The following is a description of a gene set: Human Gene Set: MIR1266_3P from publication Chen Y, Wang X (PMID 31504780) Genes predicted to be targets of miRBase v22 microRNA hsa-miR-1266-3p in miRDB v6.0 with MirTarget v4 prediction scores > 80 (high confidence targets). studied in species Homo sapiens, and this is the list of marker genes: DDX3X, RAP2A, TANGO6, ATP6V1A, BHMT2, FZD2, ZPR1, FLG2, TRAM1, SNRNP27, UQCR11, AMOTL1, PPP4R2, POGLUT3, SIX4, CDH13, FAM118A, CCT5, AOPEP, ABCB10, SENP6, GTF2H5, MYO1B, ZNF227, USP8, TAF5, CXCL2, RAB23, KCND2, RIOK3, TNRC6B, RNF214, KIAA1549L, ASXL2, CCNT2 (cyclin T2), CDKAL1, NCKIPSD, RFC3, DLD (NCBI Gene Id 2654, dihydrolipoamide dehydrogenase), TRIM55 (NCBI Gene Id 84675), FOXD4L5, CPSF6, PRKCA, HS6ST2, GJB1, RPL32, RNF146, CCT6A, FNDC1 (fibronectin type III domain containing 1), CLEC4A, LRRN2 (leucine rich repeat neuronal 2), AXIN2, PDE12, MET, EPB41L2